Given this list of marker genes Ska3, Spdl1, Ankfn1, Spire1, Kat5, Gpsm1 (G-protein signalling modulator 1 (AGS3-like, C. elegans)), Cdk5rap2, Gja1, Llgl1, Inppl1, Dync1h1, Ndel1, Mad2l1, Fgf10, Zbed3, Kash5, Hdac3, Gpsm2, Htt, Enkd1, Clasp2, Fmn2, Bccip, Mos, Pax6, Pafah1b1, Map4, Aspm, Nsfl1c, Plk1, Spire2 (NCBI Gene Id 234857), Myh9, Sapcd2, Kpnb1, Itgb1, Actr3, Fbxw11, Cenpa, Nusap1, Spry2, Arhgef2, Mapre1, Llgl2, Clasp1, Actr2, Ska2, Ccdc66, Ooep, Nde1, Spag5, Spry1, Wasl, Tle6, Dctn1, Mcph1, Zw10, Ndc80, Numa1, Ubxn2b (UBX domain protein 2B), Dynlt1b, Cfl1, Ska1, Nlrp5, Misp, Pkhd1, here is a description of the gene set: species: Mus musculus Any process in which is the spindle is transported to, and/or maintained in, a specific location. Mouse Gene Set: GOBP_SPINDLE_LOCALIZATION